The following is a description of a gene set: Abnormal blistering of the skin species: Homo sapiens The presence of one or more bullae on the skin, defined as fluid-filled blisters more than 5 mm in diameter with thin walls. Human Gene Set: HP_ABNORMAL_BLISTERING_OF_THE_SKIN, and this is the list of marker genes: IL12A-AS1, SMARCAD1, LAMC2, SPEN, SKI, PKP1, BLM, WRAP53 (WD repeat containing antisense to TP53), KDSR, RUNX1, ERAP1, DSP, KRT9, MMP23B, RTEL1, COL2A1, CLCN7, KRT16, IKBKG, NPM1, IL23R, LAMA3, CLTRN, DST, FOXP3, KRT1, CAST, HSPG2, DSG3, PRDM16, KRT17, RECQL4, SLC6A19, GATA1, MEFV (MEFV innate immunity regulator, pyrin), UROS, TGM5, USB1, UBAC2, ITGA6, NOP10, FERMT1, MMP1, BRAF, GJB3, KRT14, GABRD, KRT2, UROD, UBE4B, FAS, COL17A1, CSTA, PPOX, CDSN, IL12A, KRT6B, HLA-DQB1, TYMS, IKZF1, TNFSF11, STAT4 (signal transducer and activator of transcription 4), CCR1, RERE, TERT, HLA-DRB1, TCIRG1, IL10, ASXL1, SRSF2, IFNGR1, TLR4, SLC39A4, GJB4, FBXO28, HLA-B, KCNAB2, KRT10, KLHL24, CD151, TERC, ITGA3, ANAPC1, PTPN6, CBL, PLEC, CASZ1, AQP5, PARN, NAXD, GJA1, ITGB4, DSG1, TET2, ECM1, SNX10, LUZP1, EXPH5, CTC1, KRT5, TINF2 (TERF1 interacting nuclear factor 2), JUP, C4A, KLRC4, CPOX (NCBI Gene Id 201541), PRKCZ, KIT, PDPN, DNA2, DSC3, CYP26C1, LAMB3, NHP2, KRT6A (NCBI Gene Id 93086), COL7A1, DKC1